The following is a description of a gene set: Each fraction of mouse hematopoietic cells was purified by cell sorting from bone marrow of 8-week-old C57BL/6 mice, and its gene expression was analyzed. Genes up-regulated in comparison of neutrophils versus monocyte macrophages. Human Gene Set: GSE27786_NEUTROPHIL_VS_MONO_MAC_UP from publication Konuma T, Nakamura S, Miyagi S, Negishi M, Chiba T, Oguro H, Yuan J, Mochizuki-Kashio M, Ichikawa H, Miyoshi H, Vidal M, Iwama A (PMID 21540074) species: Homo sapiens, and this is the list of marker genes: SIPA1L1, SIRT7, RP2, RIT1, DCK, LDAF1, ZNF217, LMO2, ZDHHC4 (zinc finger DHHC-type palmitoyltransferase 4), HERPUD2, BBS2 (NCBI Gene Id 583), DNAH6, NFE2L2, LGALS9B, HCST, SIRT2, CYSTM1, HSPB2, NDUFA13, TACC1, IDH2, SYT17, GOLGA2, PALS1 (NCBI Gene Id 64398), RAB5IF, ARFIP1 (NCBI Gene Id 27236), MFSD14A, TOX4, MAGED1, C1orf122 (NCBI Gene Id 127687), TSPYL4, PITHD1, CSF3R, PAG1, B3GNT2, FAM120B, YIPF1, ADAMTS5, PADI4, ARHGAP45, MBP, CASP4, NHERF1, TMEM131, OVCA2, TFCP2L1, C5orf63, YWHAB, NSDHL, ARHGEF4, SLC16A12, CLK3, NSMF (NMDA receptor synaptonuclear signaling and neuronal migration factor), HELZ2, MPC1, CTTNBP2, RBM42, CYP4B1, BEST1, DENND1C, UBL3, TNFRSF21, BET1L, C22orf39, MYO1F, STRN3, WDR77, SDF4, PTBP3, PTCRA, COA5, RASSF3, MIEF2, RAD51D, GSDMD, TMEM50A, DDX47, SIX6, RAP1GDS1, NLK, ZFHX4, IDUA, MTNAP1, SERTAD2, CCNL2, SLITRK6, NFE2, CERS2, UNC13B, YAF2, PAIP2, HACD4, CMPK2, RGS19, DQX1, CEP20, ZCCHC2 (zinc finger CCHC-type containing 2), ARPC5, ABI1, ZNRF1, DHRS1, UQCRC2, ACADM, SH3GLB1, ZNF652, ASNSD1, FOXO3, ZBTB24, PAM (peptidylglycine alpha-amidating monooxygenase), ELMOD3, ALOX12, FGD4, ARL3, EVI2B, D2HGDH (NCBI Gene Id 728294), H3C14, PLEKHG3, ANKS3, DCTN2, TSPAN13, SREK1IP1, CDC34, ING4, BMPR1A (bone morphogenetic protein receptor type 1A), TATDN1 (TatD DNase domain containing 1), TRAPPC8, NR3C1, CRYBG1, SLC15A3, ITPRIP, CD37, ZNF124, PCOLCE, TWF2, RGS5, TBC1D17, RSAD2, C1QTNF9, MAPK3 (mitogen-activated protein kinase 3), AGBL5, MIEN1, ZNF319, ZMYM2, MINDY1, PAQR4, NCF1, IQSEC1, JUNB, MYL2, AKNA, MIA3, SHC4, MSMO1, ATP6AP1, TP53INP2, RAB20, VNN1, RBFA, PDZRN4, OLFM4, CCDC88C, LTF, ZMAT2, DGKA, CILP, CLEC4E, CDK13, SENP2, TAP2, IFT46, ARG2, IPCEF1, LAMTOR4, CTSD, CDKN2AIP, PFKM, MARCHF4, G0S2, PNPLA1, C9orf78, CACNG2, MGAT5B, LGI4, CNR1, FCGR3A, SMOX, PRKAR1A, EXOC7, SON, TRMT9B, SELENON, MTUS1, SPI1 (Spi-1 proto-oncogene), VSIR, AMFR, TTPAL, ATF7IP, RCSD1, NAT8 (N-acetyltransferase 8 (putative))